The following is a description of a gene set: Mouse Gene Set: DESCARTES_ORGANOGENESIS_INTERMEDIATE_MESODERM Mouse Organogenesis Cell Atlas (MOCA) DE_gene_main_cluster.csv, fold.change>=1.5, qval<0.05, pval<0.05 studied in species Mus musculus from publication Cao J, Spielmann M, Qiu X, Huang X, Ibrahim DM, Hill AJ, Zhang F, Mundlos S, Christiansen L, Steemers FJ, Trapnell C, Shendure J (PMID 30787437), and this is the list of marker genes: Wt1os, Akr1cl, Gm10400 (NCBI Gene Id 100093700), 4933433G15Rik, Fendrr, Muc16, Pmp22, Colec10, Nkx2-3, Cxcl13, Barx1, Myrf, Sntg2, Gm21814, Got1l1, Arhgap22, Lrrn4, Sptssb, Ak5, Amhr2, Tcf21, Rarres2, Bnc1, Wt1, Gm15675, Myh11, Rep15 (RAB15 effector protein), Cobl, Actg2, Adamts13, 8430419K02Rik, Zfp775, Or2y7, Crispld2, Foxf1, Hdnr, Gm28523, Sycp1, Nr1h5, D030025E07Rik, Kctd14, Upk3b